Given this list of marker genes PTPN6, C1QB, WAS, NOD2, TBK1, DNASE1L3, PNP, MEFV, POLR3F, IL12RB1, ARPC1B, TREX1, HCK, PGM3, SYK, LYN, DOCK8, here is a description of the gene set: studied in species Homo sapiens Vasculitis by anatomical site Vasculitis categorized according to the anatomical site where the finding is localized. Human Gene Set: HP_VASCULITIS_BY_ANATOMICAL_SITE